Given this list of marker genes SHH, TPRKB, CAPRIN1, ATP6AP1, RLIM, DPM2, RNF113A, KDM6A, DPYSL5, GON7, POLR3A (NCBI Gene Id 11128), COX14, EVC, TP53RK, TGIF1, DCLRE1B, IFT52, PI4K2A, RERE, FGFR2, EVC2, RTTN (rotatin), ARID1B, PLCH1, RAB3GAP1 (NCBI Gene Id 338380), SIX3, ARCN1, NUP107, GSC, NUP133, CTCF, EBF3, GLI2, ZNF699, SUFU, LAGE3, FGFR3, KAT8, PPP1R15B, TRMT10A, GJA1, NSUN2, CEP57, XRCC4, GPT2, GATA2, DISP1, YRDC, HNRNPH2, MLXIPL, RNU4-2, NDP, CCDC32, ERCC2, FREM1, HNRNPC, CRIPTO, STAG2, CNOT1, MPLKIP, PRPS1, SLC4A10, FGF8, DLL1, PRKAR1B, GGT1, ABCC9, GTF2E2, NODAL, POLRMT, CUX1, RAD21, CNOT3, RAB3GAP2, KIF26A, PAH, MSX2 (msh homeobox 2), SHPK, DDB1, OSGEP, FARSB, LIG4, SMPD4, KANSL1, SMC1A, GAS1, WDR4, DYRK1A, CLCN3, MKS1, GNB2, STIM1, NF1, IFT43, ACBD5, ALDH18A1, FANCD2, AARS1, TWIST1, OPHN1, SNRPN, PDGFRB, PYCR1, CDK19, CAMK2A, CILK1, MSTO1, SLC35A1, ERCC3, SEPTIN9, CDON (cell adhesion associated, oncogene regulated), QARS1, RECQL4, FGFR1, STIL, TRRAP, PDE4D, GJA8, TRAPPC9 (NCBI Gene Id 83696), SRC, FOXH1, NIN, PTCH1, USP9X, IFT122, NARS1, AP3D1, NDE1, WDR19, FKBP14, PROKR2, WDR73, BLTP1, ELN (elastin), KMT2D, GJA5, HUWE1, EPG5, WDR35, NTNG2, AASS, BICRA, TARS1 (NCBI Gene Id 94887), GTF2H5, KCTD1, ZIC2, CARS1, here is a description of the gene set: Hypotelorism Interpupillary distance less than 2 SD below the mean (alternatively, the appearance of an decreased interpupillary distance or closely spaced eyes). species: Homo sapiens Human Gene Set: HP_HYPOTELORISM